The following is a description of a gene set: studied in species Homo sapiens Human Gene Set: HP_MESOAXIAL_HAND_POLYDACTYLY The presence of a supernumerary finger (not a thumb) involving the third or fourth metacarpal with associated osseous syndactyly. Mesoaxial hand polydactyly, and this is the list of marker genes: FAM149B1, MKKS, TWIST1, LZTFL1, RAB34, MAP3K20, GLI3, TFAP2B, CPLANE1, HOXD13, FGFR2, IFT27 (intraflagellar transport 27), CHSY1